Given this list of marker genes Rdh10, Tmtc3, Tfap2c, Bmp4, Fgf1, Spry2, Six1, Med1, Fgf10, Sox9, Areg, Spry1 (sprouty RTK signaling antagonist 1), Tgfb1, Tnc, Hoxd13, Hnf1b, Six4, Esr1, Shh, Fgfr2, Wnt5a (wingless-type MMTV integration site family, member 5A), Yap1, here is a description of the gene set: Mouse Gene Set: GOBP_BRANCH_ELONGATION_OF_AN_EPITHELIUM The growth process in which a branch increases in length from its base to its tip. studied in species Mus musculus